Given this list of marker genes MAGEE1, FOXC2, COL1A2, PFN2, TIMP1, SDC4, CXCL8, THY1, GJA1, BASP1, VCAM1, LAMA3, DPYSL3, VIM, LAMC2, GREM1, AREG, WNT5A, SPARC, TGFBR3, DAB2, SLIT3, MCM7, PCOLCE, MMP1, CDH2, LGALS1 (NCBI Gene Id 3956), MYL9, PLAUR, FMOD, ENO2, CDH6, GPX7, CD59, TNFRSF12A, THBS1, FZD8, NNMT, COL12A1, TGFB1, TGM2, SERPINE1 (serpin family E member 1), MSX1, SLIT2, LOX, COL4A1, MGP, ANPEP, ITGB3, CALU, SNAI2, PPIB, ITGA2, PDGFRB, VEGFA, ID2, CD44, MYLK, COL5A1 (collagen type V alpha 1 chain), COL4A2, IL6, NID2, MFAP5, MXRA5, COL5A3, COMP, FAS, LOXL1, EDIL3, COL11A1 (NCBI Gene Id 317718), LOXL2, IGFBP4, COL1A1, IGFBP3, NTM, BMP1, APLP1 (amyloid beta precursor like protein 1), ITGB1 (integrin subunit beta 1), MATN2, FSTL1, SFRP4, THBS2, FERMT2 (FERM domain containing kindlin 2), CXCL6 (NCBI Gene Id 6372), CCN1, FN1, SCG2, PCOLCE2, FBLN1, ECM2, GADD45A, CADM1, LAMC1, PVR (PVR cell adhesion molecule), HTRA1, NT5E, WIPF1, FBLN2, COL16A1, VEGFC, PRRX1, PLOD1, PLOD2, ACTA2, NOTCH2, SDC1, CCN2, COL6A2, ITGB5, ITGA5, PTX3, PMEPA1, RGS4, COLGALT1, MMP14, FLNA, CDH11, COL8A2, ABI3BP, PDLIM4, IGFBP2, FUCA1, MMP2, TNC, SGCG, FBN2, FBLN5, CALD1, COL6A3, MMP3 (NCBI Gene Id 4314), P3H1, TAGLN, GEM, COL7A1, DKK1, MATN3, CRLF1, TPM2, TGFBI, SAT1, RHOB, LAMA2, FBN1, MEST, FAP, FGF2, GADD45B, EFEMP2, DST, COPA, LUM, COL3A1, SGCD, OXTR, LAMA1, ITGAV, BGN, SLC6A8, ELN, INHBA, QSOX1, LRP1, GLIPR1, ECM1, TFPI2, FSTL3, SERPINH1, CXCL1, TPM1, ADAM12, GPC1, DCN, POSTN, PMP22, VCAN, CAPG, SPOCK1, TPM4, SGCB, IL32 (interleukin 32), BDNF, TIMP3, PRSS2, GAS1, PLOD3, EMP3, COL5A2, LRRC15, IL15, CTHRC1, CAP2, SERPINE2, PTHLH, TNFAIP3, SFRP1, SNTB1, TNFRSF11B, SPP1, CXCL12, JUN, here is a description of the gene set: Genes defining epithelial-mesenchymal transition, as in wound healing, fibrosis and metastasis. Human Gene Set: HALLMARK_EPITHELIAL_MESENCHYMAL_TRANSITION from publication Liberzon A, Birger C, Thorvaldsdóttir H, Ghandi M, Mesirov JP, Tamayo P (PMID 26771021) species: Homo sapiens